Given this list of marker genes AMDHD2, EDA, ART1, HAND2-AS1, MYCL, AQP8, TMED3, PLEKHG3, XRCC4, AGTR2, DPP6, NUAK1, TLN2, CYP4B1, SLC22A4, CD1C, WDFY3, DCN, MYOF, ABCG5 (ATP binding cassette subfamily G member 5), HFE, RGS11, CPNE1, AK4, DPY19L1, ADGRA3, PLAAT1, CD84, CITED1, KCNG1, SLC9A8, CLSTN2, ADORA1, SULT4A1, UNKL, PIGZ, ANKRD7, MTF1, KDELR3, FOLH1, SLC9A5, SSTR5, BMP2, OR10C1, CABP5, MYOG, CISD1, KRT19P2, PLCB4, APOC2, CKM, KLHL23, KCNK2, ABCG4, CHI3L1, ACSBG2, BMAL2, CHIA, KRT9, HPD, AGPAT2, SLC44A4 (NCBI Gene Id 87892), ZMAT4, COL15A1, UBIAD1, CYP2C19 (cytochrome P450 family 2 subfamily C member 19), NPAP1, GOT2, RAB23, FER1L4, SCNN1B, SARS2, LRRN3, IL19, PRM1, PPM1G, SCRG1, MTMR7, RAB2A, NFAT5, COL5A3, PCDHGA9, TTLL7, SLC35G2, SLCO1B3 (NCBI Gene Id 28234), COA7 (cytochrome c oxidase assembly factor 7), PLXNB3, CEACAM6, SPRR2B (small proline rich protein 2B), PRRC1 (proline rich coiled-coil 1), MANF, YWHAH-AS1, SIDT1, MET, ATP7B, SEMA6D, LRRC32, IL6R, MYL3, OLA1, OR7A5, CPA2, OPCML, KLRK1, CDH22, IFI35, LAMB2, CHRNA2, MPST, C14orf132, OR2J2, LINC00939, CDC25C, MALL, NIPAL2 (NCBI Gene Id 79815), KCNJ5, DSG2, BMAL1, RBPMS (NCBI Gene Id 11030), FGF7, KLK7, HSD3B2, EYA1, PRAMEF10, MYL4, POFUT1, MRPS7, AGMAT (NCBI Gene Id 79814), LGALS4, HINT1, HBBP1, ERC2, NRBP1, LGR5, KRT3, SLC39A2, ADGRG2, TMBIM6, UCHL1, OLFML2A, SLC17A1, COPE, SPACA1, NPBWR2, GABRB1, SERGEF, SYP, FOXO3, GNRH2, DIAPH1, CRHR1, CLDN6, NAALADL1, GLYAT, LDHAL6B, MYH7B, MPP3 (NCBI Gene Id 4356), MAB21L1, CCND1, IVD, SPAG11A, PLCH1, GDF5, SCGN, MEPE, SNF8, HPCAL4, COL18A1, E2F2, CACNG2, KANK1, KLK15 (NCBI Gene Id 92788), FNTB, DDRGK1, AEBP1, FAH, STC1, PPFIBP2, EPB41L5, LHB, DPT, COLQ, GPR161, SEMA3F, NLGN4X, GPR20, CEACAM1 (NCBI Gene Id 634), RAI2, WNT8B (NCBI Gene Id 7479), SLC27A5, RPRM, GM2A, KLHL1, here is a description of the gene set: Genes up-regulated in comparison of IgM-memory B cells versus Ig isotype switched memory B cells. species: Homo sapiens Human Gene Set: GSE13411_IGM_VS_SWITCHED_MEMORY_BCELL_UP from publication Good KL, Avery DT, Tangye SG (PMID 19124732) Enhanced secondary Ab responses are a vital component of adaptive immunity, yet little is understood about the intrinsic and extrinsic regulators of naive and memory B cells that results in differences in their responses to Ag. Microarray analysis, together with surface and intracellular phenotyping, revealed that memory B cells have increased expression of members of the TNF receptor, SLAM, B7 and Bcl2 families, as well as the TLR-related molecule CD180 (RP105). Accordingly, memory B cells exhibited enhanced survival, proliferation and Ig secretion, as well as entered division more rapidly than naïve B cells in response to both T-dependent and T-independent stimuli. Furthermore, both IgM and isotype switched memory B cells, but not naïve B cells, co-stimulated CD4+ T cells in vitro through a mechanism dependent on their constitutive expression of CD80 and CD86. This study demonstrates that upregulation of genes involved in activation, co-stimulation and survival provides memory B cells with a unique ability to produce enhanced immune responses and contributes to the maintenance of the memory B cell pool.